Given this list of marker genes IBA57, RNF169, NECTIN3-AS1, SEPSECS, TACC1, ING3, R3HDM2-DT, SLK, GRHL1, SGPP1, UBE2E2-DT, ABCD3, NF2, MAPK8IP2, YTHDC2, HSDL2-AS1, ITGB1, EPAS1 (NCBI Gene Id 2034), ACTR6, TPTEP1, ENO3, ZNF628-DT, WDR45B, FBXW11, EOLA1, OTUD4, KMT5B (NCBI Gene Id 54794), PBX3, EOLA2, AMPD3, IRAK4 (NCBI Gene Id 95458), NEUROD4, SLC44A1, ENTPD8, GIT1, C8orf88, CDK13, PRKD3-DT, GALC, RTF2, MIPEPP3, PBRM1 (NCBI Gene Id 55292), PRKD3, PSTPIP2, FKBP1A, PRKAR2A-AS1, UBE3C (ubiquitin protein ligase E3C), DUSP5, VIM, MYL9, ECHDC3, NECTIN3, THOC1-DT, IBA57-DT, BCAR3, FCHSD2, C11orf71, MBTPS2, ESPN, TMEM161B, DBIL5P, PPP1R21, PNPLA7, USP3, USP46, MIR7-3 (microRNA 7-3), TUBB6, MIR7-3HG, VPS37A, RTN4RL2, RCAN1, PRMT9, ZNF264, RNF130, MAFG, LRRC27 (NCBI Gene Id 92295), NMBR, PDE8A, API5, EOLA1-DT (EOLA1 divergent transcript), METTL4, CAPN12, ATG3, NADK, RELN, POU3F2, JAG1, SNAP25-AS1, ZNF497-AS1, SOCS2, FOXJ3, EOLA2-DT, KXD1, GPRIN1, TENT5B, KMT2C, D2HGDH, GPR160, NCOA5, CLCN3, MTIF3, GMPPB, SRRM2-AS1, KSR1, EIF5B, CINP, TXNDC9, RPUSD1, G2E3 (NCBI Gene Id 55632), TES, DRAP1, DCBLD1, CDC42BPG, CSGALNACT2, PTGDS, ZNF547, UBR7, GNB1, UBE2V2, PBX3-DT, ADRA2B, FOXA3, NBEA, RB1-DT, ATRN, CHSY1, ERO1B, SUZ12P1, AFDN-DT, CCDC138, IMPDH2, RNA5SP60, HES6, LINC03021, MUTYH (mutY DNA glycosylase), VPS16, CREBBP, MIR3188, BARHL1, MRPL13, MIR212, ACVR1C, SLC12A2-DT, ZNF396, RCL1, R3HDM2, ESCO1, THOC1, EVL, PFN1, RNASEH2A, INTS6L, LDHA, TRIM33, PUS7L, PHLDA2, CFDP1, PPM1E, CTDP1-DT, CBFB, EIF5, TFEB, DECR2 (NCBI Gene Id 57382), APPBP2-DT, CLK2, OPA3, NDUFAF6, LIAS, MTBP, MVB12A, UBB, GNB1-DT, UBE2I, DNMT3A, RANBP2, FAM53A, PGBD2, AHCYL1, SEPTIN7, CDC42, KANK1, CRYBB2P1, SLC25A29, PPP1R13L, C21orf91, SIGIRR, RAB33B, PHF6, ETV3, CCDC7, CTHRC1 (collagen triple helix repeat containing 1), TANGO2, PAPOLA-DT, HAGH, MALAT1, INTS6L-AS1, GPSM2, PSMD14, A1BG-AS1, SPACA9, MILIP, TP53INP1, HILPDA-AS1, METTL26 (methyltransferase like 26), FIGNL1, PAPLN-AS1, ADGRB3, AFDN, GUF1, CAND1 (NCBI Gene Id 55832), BCL6, HTR5A, EIF3A, GNL3, WRNIP1, COG1, DUSP10, LHPP, TULP4, ZNF540 (NCBI Gene Id 163255), RTBDN, CCDC63, SRRM2, NMUR1, TPBGL-AS1, RGS12, PLEKHF2, ZNRF2, SLC12A2, HES2, SYNCRIP, MRFAP1, LZTS3, SMIM2-AS1, ADSS1, RRBP1 (NCBI Gene Id 6238), VAPB, MCAT, MIR378D2HG, SUPT20H, SPCS2, PRKAR2A, PPP1R21-DT, BICD2, PDP1, FGFR4, TXNL4A, TOE1, SYMPK, HILPDA, IKBIP, EIF4A3, TRAPPC2B, ZNF571, RPL9, SNAP29, IFT52, HSD11B1L, MARVELD1, MAP3K1, BCAS2, PI4KA, RPS9, ATXN2L, ADAMTS7, UBE2E2, FAHD1, CYB5R4, RHPN2, CA5BP1, DOT1L, KANK3, SEPSECS-AS1, PTPN21, IL11, PLEKHG4 (NCBI Gene Id 6312), LSR, LTBP4 (latent transforming growth factor beta binding protein 4), ARL8B, MCRIP2, NEAT1, MVP-DT, MIR132, C11orf68, YTHDC1, SYNM, JUND, VRK3, SLC35A5, CTDP1, RABGAP1, MIR5188, APPBP2, PGF, PPP1R2, PGRMC2, PAPOLA, GPR153, SNHG15, RPL14, TRIM58, GPR157, FOXK2, DNAAF3, PDE4C, CTNNB1 (NCBI Gene Id 1499), CASKIN2, ZNF628, RBM7, PLLP, B3GLCT, PNPLA3, TRIM47, FABP5P3, STUB1-DT, XRRA1 (NCBI Gene Id 143570), WNT1, MTO1, TENT5A, TMEM168, SPOP, UBC, MOB4, STK32C, CHTF18, CPEB1, ZNF711, TMEM250, ORC5, CNOT7, ZNF473, NDC80 (NCBI Gene Id 10403), CHRNB4, CPEB1-AS1, POLR1G, RTRAF, LHFPL5, POMGNT2, AHDC1, TMEM161B-DT, GEMIN4, GUSBP11, TSEN54, STXBP3, STUB1, TAMM41, SLBP, ANKRD63, KIF17, PRRT2, PSMD14-DT, APAF1, LINC00466, FOSB, CARD10, CRACD, FNDC3B, RHBDD1, ARHGEF19, THRAP3, NIBAN1, SNX12, here is a description of the gene set: Genes containing one or more binding sites for (NCOA6) in their promoter regions (TSS -1000,+100 bp) as identified by GTRD version 20.06 ChIP-seq harmonization. Human Gene Set: NCOA6_TARGET_GENES species: Homo sapiens from publication Yevshin I, Sharipov R, Kolmykov S, Kondrakhin Y, Kolpakov F (PMID 30445619)